The following is a description of a gene set: Mouse genes annotated to increased T cell derived lymphoma incidence (MP:0002024) retrieved from the Mouse Genome Informatics database via MouseMine from publication Motenko H, Neuhauser SB, O'Keefe M, Richardson JE (PMID 26092688) species: Mus musculus Mouse Gene Set: MP_INCREASED_T_CELL_DERIVED_LYMPHOMA_INCIDENCE, and this is the list of marker genes: Brca1, Crebbp, Cdkn1a, Mcm4, Trp73, Uimc1 (NCBI Gene Id 77298), Srpx, Lin28b, E2f1, Prkdc, Lck, Cntn2, Mir125b-1, Hip1, Myc, Skil, Cdkn2a, Pten, Tgfbr2, Trp53bp2, Prf1, Map3k8, Mtf1, Nabp2, Pim1, Spi1, Runx1, Atm, Zeb1, Smarcb1, Tcf3, Msh2 (mutS homolog 2), Lig4, Trp53 (transformation related protein 53), Mir146, Mgmt, Hace1, Fbxw7, Fdxr, Mdm2 (transformed mouse 3T3 cell double minute 2, NCBI Gene Id 69330), Pml, Rad50, Rnf8, Kras, Il9, Notch3, Ndrg2, Akt2, Nbn, Mir22, Id1, Mlh1, Xrcc6, Notch1, Prdx1, Cop1, Trp53bp1, Ikzf1, Stk38, H2ax (H2A.X variant histone), Pold1, Ifng, Atad5, Brca2, Rc3h1, Pole4, Bmf, Egr1, Chd2, Cdkn2c, Pms2 (PMS1 homolog2, mismatch repair system component)